The following is a description of a gene set: Genes having at least one occurrence of the motif YRNCAGGAAGYRNSTBDS in the regions spanning 4 kb centered on their transcription starting sites. This matches the ELF2 transcription factor binding site V$NERF_Q2 (v7.4 TRANSFAC). species: Homo sapiens Human Gene Set: NERF_Q2, and this is the list of marker genes: MTF2, NLK, CREB3, LSAMP, GPR107, TWIST1, MDFI, SDCCAG8, ROBO4, LANCL1, ROM1, ARHGDIB, EIF3K, KCND1, SHROOM1, GPR132, SALL1, SPIB, FCER1G, PEX11B, LYN, LYL1, MAP4K1, FGR, ARHGAP30, FCGR2C, BAHD1, ATOH8, STARD8, USP5, EGR3, CIDEC, RPS3, CNOT11, LAYN, BCOR, FCGR2B, MIR137HG, RANBP1, SLC30A7, JPT1, EMSY, SLITRK6, TPP2, NRP1, CLIC1, NTRK3, FASTKD5, SPEG, FBLIM1, LOXL3, UBTF, CCDC85B, SKAP1, CAP1, MAP2K6, HCLS1, NUFIP2, SRPRA, LAT, ST7L, CAMK1D, RFTN2, BMP4, SHC3, FOXRED1, CD79B, JAG1, DOK1, CD79A, ARAP1, GPR25, RGS3, ITPKB, ZNF768, STARD13, IL11RA, CORO1A, CHD2, HBEGF, SNCG, LST1, MIDEAS, ZNF276, YRDC, CPNE8, NFIA, TNFAIP8L2, RHOV, IWS1, P3H4, SH3TC1, SH3TC2, EFHB, ZBTB7B, AGL, VPS45, PTPN6, RASAL1, FBXO36, GRM3, GOLGA7, UBE2L3, JUNB, FLT1, RPS6KA4, EGFLAM, COLQ, MCTS1, RMC1, PTPRN, RBBP7, HYAL2, ST13P4, TRMT2A, ZFPM1, VCL, FURIN, NHSL2, NRXN3, AAMDC, NCLN, FAM110A, EXTL2, ARL4C, POU6F2, NAT8L, SARAF, OMA1, CAPZA1, NFATC3, CNPY2, GGNBP2, HIC1, CDCA3, EML3, TCF12, PIK3CG, LRRC41, CCR10, LYPLA2, C1orf122, GSKIP, FOSL1, TFRC, SLCO2B1, CNTNAP1, EBAG9, RBMS2, FKBP10, LIMD2, GNRHR2, ERG, AGPAT1, HOXB9, ATP5PD, GSDMA, NIPAL2, DEF6, ARHGAP8, UQCRH, CALM2, UCHL5, ZMYND8, GPR162, SPRED2 (sprouty related EVH1 domain containing 2), CLVS1, PAX6, LLGL2, CPXM1, ELOVL5, SLX4, CNNM1, NPY, KDF1, FAAP100, DPP3, MPL, PEX16, C2orf42, MSANTD2, ITPR3, PPP1R9B, ZHX2, OLFML2A (olfactomedin like 2A), DIABLO, TRAPPC3, MMRN2, XKR8, TGIF2, GMFB, TNS2, POU4F3, STAT5A, C1QTNF6, TNFRSF6B, PITX2, FXYD5, MYO19, MAPK3, SYNC, POLD4, RO60, DDIT3, EDEM3, MID1, SH2D2A (NCBI Gene Id 9047), FHIP1B, LRRFIP2, FBRS (NCBI Gene Id 8734), RASA1 (NCBI Gene Id 5921), CDK5, GBF1, TUSC3, NDUFS2, ACTR3 (actin related protein 3), PCDH7, ATP1A1, SLC43A1, HMGA1, ARHGAP20, PIGW, SORBS1, ARRB2, CD40LG, ZNF800, CREBZF, SECISBP2 (NCBI Gene Id 79048), GGT7, TOPORS, SEMA4C, PAK3, TRO, NCS1, STAT5B, WDFY4, ZMAT3, ADAMTSL3, BAZ2A, KLF13, FGFR2, HMGN2, PLCB2, ARAP3, SLC4A2, ZNF23, HOXC4, DPP8, ADAMTS4, ELK3, TLN1, IKBKB, ATOSB, EFNA1, RSF1